The following is a description of a gene set: Catalysis of the reaction: an adenosine in mRNA + S-adenosyl-L-methionine = an N(6)-methyladenosine in mRNA + H+ + S-adenosyl-L-homocysteine. This activity is the methylation of adenines in mRNA with the consensus sequence RRACH, where R is a purine, and H is C, A, or U. Mouse Gene Set: GOMF_MRNA_M_6_A_METHYLTRANSFERASE_ACTIVITY studied in species Mus musculus, and this is the list of marker genes: Mettl14, Tmt1a2, Mettl3, Tmt1a3, Tmt1a, Mettl16